The following is a description of a gene set: species: Mus musculus Mouse Gene Set: GOMF_ACTIVE_MONOATOMIC_ION_TRANSMEMBRANE_TRANSPORTER_ACTIVITY Enables the transfer of an ion from one side of a membrane to the other up the solute's concentration gradient. This is carried out by binding the solute and undergoing a series of conformational changes. Transport works equally well in either direction., and this is the list of marker genes: Ndufs8, Uqcrh, Ndufs4, Atp6v0a4, Atp13a5, Atp7a, Atp6v1f, Atp6v0e2, Atp1b2, Atp6v1b2, Atp6v1g1, Cyc1, Atp2a3, Atp5f1e, Ndufs1, Atp2c2, mt-Nd4, Atp6v0a1, Ndufv1, Atp6v0d2, Atp12a, Atp6v1d, Cox4i2, Atp6v1b1, Atp2b4, mt-Nd1, Abcc9, Atp13a2, mt-Nd3, Atp6v1g3, Atp6v0a2, Ndufa2 (NADH:ubiquinone oxidoreductase subunit A2), Ndufa10, Atp2b1, Atp1a2, Atp6v1c2, Atp2a2, Atp6v1g2, Uqcrh-ps1, Atp13a4 (ATPase type 13A4), mt-Nd5, Cox7a1, Atp4a, Atp13a3, Atp5mg, Atp6v1e1, mt-Nd4l, Atp6v1h, Ndufs2, Atp5f1b, Atp2c1, Kcnj11, Atp2b3, mt-Co3, Ndufb7, mt-Cytb, Kcnj8, Abcc8, Ndufs3 (NCBI Gene Id 68349), Atp1b3, Atp6v1c1, Tmem94, Ndufs7, Atp6v1a, mt-Nd2, Nnt, mt-Co1, Atp6v0b, Atp6v1e2, Atp2a1, Atp1b1, Atp13a1, Uqcrfs1, Atp6v0c, mt-Nd6, mt-Co2, Ndufv2, Atp7b, Atp6v0e, Atp1a4, Atp2b2, Anxa5, Atp1a1, Cox5a, Atp6v0d1, Atp4b, Surf1, Atp1a3, Cpox